The following is a description of a gene set: Genes down-regulated in peripheral blood mononuclear cell stimulated vs unstimulated in adults (18-40) after exposure to Dryvax, time point 1 to 48M. Comment: top differentially expressed genes, more avail in Suppl Materials studied in species Homo sapiens from publication Kennedy RB, Oberg AL, Ovsyannikova IG, Haralambieva IH, Grill D, Poland GA (PMID 23594957) Human Gene Set: KENNEDY_PBMC_DRYVAX_AGE_18_40YO_STIMULATED_VS_UNSTIMULATED_1_TO_48MO_TOP_DEG_DN Despite its eradication over 30 years ago, smallpox (as well as other orthopox viruses) remains a pathogen of interest both in terms of biodefense and for its use as a vector for vaccines and immunotherapies. Here we describe the application of mRNA-Seq transcriptome profiling to understanding immune responses in smallpox vaccine recipients. Contrary to other studies examining gene expression in virally infected cell lines, we utilized a mixed population of peripheral blood mononuclear cells in order to capture the essential intercellular interactions that occur in vivo, and would otherwise be lost, using single cell lines or isolated primary cell subsets. In this mixed cell population we were able to detect expression of all annotated vaccinia genes. On the host side, a number of genes encoding cytokines, chemokines, complement factors and intracellular signaling molecules were downregulated upon viral infection, whereas genes encoding histone proteins and the interferon response were upregulated. We also identified a small number of genes that exhibited significantly different expression profiles in subjects with robust humoral immunity compared with those with weaker humoral responses. Our results provide evidence that differential gene regulation patterns may be at work in individuals with robust humoral immunity compared with those with weaker humoral immune responses., and this is the list of marker genes: S100A9, SEMA3A, XCR1, PDCD1LG2, MYEOV, CD14, GPR84, CHST6, GPBAR1, SIRPB2 (NCBI Gene Id 284759), S100A8, KCNJ10, THBS1, APOC2, ADORA3, PRSS50, TREML4, PTGES (prostaglandin E synthase), C4BPB (NCBI Gene Id 725), CXCL6, NDP, SIRPD, ARPIN (actin related protein 2/3 complex inhibitor), MPEG1, HAMP, HNMT, ARNT2, OPRL1, LAMP5, DCANP1, IL18, BMP3, MFAP5, SYT15, PDPN